The following is a description of a gene set: Human Gene Set: GOBP_AMYLOID_PRECURSOR_PROTEIN_BIOSYNTHETIC_PROCESS The chemical reactions and pathways resulting in the formation of amyloid precursor protein (APP), the precursor of amyloid-beta, a glycoprotein associated with Alzheimer's disease. species: Homo sapiens, and this is the list of marker genes: MIR323A, NCSTN, MIR101-1, MIR298, PAWR, MIR455, MIR31, ABCA7, ABCA2, MIR106A, ITM2B, MIR644A, MIR153-1, ITM2C, MIR17, MIR147A, NECAB1, ITM2A, AGO2, MIR20A, BACE2, MIR520C (microRNA 520c), NECAB2, MIR144, AATF, SOAT1, NECAB3